The following is a description of a gene set: species: Homo sapiens The volume enclosed by the outermost membrane of a multivesicular body. Human Gene Set: GOCC_MULTIVESICULAR_BODY_LUMEN, and this is the list of marker genes: CTSH, SFTPB, NAPSA, PGA5, PGA3, SFTPC, PGA4